The following is a description of a gene set: Mouse Gene Set: MIR_7218_3P Genes predicted to be targets of miRBase v22 microRNA mmu_miR_7218_3p in miRDB v6.0 with MirTarget v4 prediction scores > 80 (high confidence targets). studied in species Mus musculus from publication Chen Y, Wang X (PMID 31504780), and this is the list of marker genes: Afg1l, Wif1 (Wnt inhibitory factor 1), Man2a1, Dr1, Palb2, Pcsk2, Helz2, Morc3, Cnnm1, Rfx7, Cnot7, Trip12, Gbp8, Prkaa1, Cacna1h, Acbd5, Moxd1, Trerf1, Ppp4r2, Dnaaf6, Naa40, Arhgap32, Dmrt3, Arfgef1, Ubtfl1, Tmem135 (NCBI Gene Id 72759), Mab21l1, Kdm7a, Dipk2a, Cops8, Prlr, Gpalpp1, Gabrg1, Btg1, Tmem170b, Wnt2, Tfrc, Bmp2k, Dnaaf6rt, Nars2, Sp5, Sp4, Stag2 (NCBI Gene Id 78442), Ap1s1, Acer3, Fen1, Gabpa, Pgbd5, Kcnk1, Zfp979